Given this list of marker genes ADAMTSL2, IL21R, FLRT2, DTNA, ALDOC, SEMA3E, NTN1, DUSP2 (dual specificity phosphatase 2), SLC25A4 (solute carrier family 25 member 4), C3orf70, PARM1, TMEM59L, SORBS1, FGF18, FAM43A, PMEPA1, BEX1, ADGRE5, SBSPON, SMOC2, PLP2, CNN1, DUSP26, RAMP1, RASSF3, FBXL22, CCDC3, SVIL, NR4A2, MAPKAPK3, LRIG1, CAVIN2, ANKRD37, NR4A3, GREM2, HSPG2, ASB2, FNDC1, THBS3, TNNT3, CCN4, GEM (GTP binding protein overexpressed in skeletal muscle), KCNK3, PRKAG2, AKAP1, SSC5D, ZBTB16, IL4R, TOB1, FENDRR, KCNMA1, FOXP4, LGR6, TYRP1, ZEB1, CCND3, RASL11A, TRANK1, HHIP (NCBI Gene Id 64399), P3H2, MRGPRF, IL17B, PPP1R12B, INKA2, AQP1, SYNC, HSPB7, ENTPD1-AS1, LIMS2, LMOD1, GADD45G, COL4A5, TSPAN18 (tetraspanin 18), ANO1, DAPK3, RBM38, KLHL4, TSPAN7, ITGA10, PDLIM4, RCSD1, GBP2, MYL4, C16orf89, CCDC88C, ARL4A, ESYT2, CXADR, CRELD1, PDLIM3, FEM1C, TRIB1, TACC2, ADAMTS5, NR4A1, PLN, SEMA3C (NCBI Gene Id 222200), INHBA, HHIP-AS1, CSRNP1, FOXP2 (NCBI Gene Id 93986), BCL11A, CAP2, EPCAM, CDH13, FBXO32, BRINP3, SYT11 (NCBI Gene Id 92303), CRISPLD2, TNNT2, MBNL1-AS1, SLC29A1, DMD, NCOA6, BMF, ACTG2, ATP1A2, ANOS1, PCSK7, CD9, ADAMTS6, MYOCD, SLC8A1, NET1, SYNPO2, COL4A6 (collagen type IV alpha 6 chain), WFDC1, THAP8, ITGA9, NCKAP5, HPSE2, KANK1, SLC16A3, KCNA5, KIAA0408, KCNMB1, C1QTNF1, PFKFB3, SPEG (NCBI Gene Id 729871), CRIP1, RRAD, LTBP2, FILIP1L, PLXNA4, WNT5A, PEDS1, PBXIP1, ADAM19, SLC2A1, GALNT18, TRAF5, LAMA5, IGF1, SYNGR2 (synaptogyrin 2), ITPK1, TSPAN2, LEFTY2, BTC, RGS10, CHRDL1, PTP4A3, THBS2, MSRB3, TCEA3, ALDH1B1, MYH11, TINAGL1, FHL2, THSD4, AK4, IRAG1, TMEM255A, PLP1, SCUBE1, PDGFC, CDKN1A, ENTPD1, MTCL1, BHLHE40, TM7SF2, PNMT, SLMAP, EGLN3, NNMT, GPR20, CDC42EP3, ADAMTS8, COLGALT2, GLRB, here is a description of the gene set: from publication He P, Lim K, Sun D, Pett JP, Jeng Q, Polanski K, Dong Z, Bolt L, Richardson L, Mamanova L, Dabrowska M, Wilbrey-Clark A, Madissoon E, Tuong ZK, Dann E, Suo C, Goh I, Yoshida M, Nikolić MZ, Janes SM, He X, Barker RA, Teichmann SA, Marioni JC, Meyer KB, Rawlins EL (PMID 36493756) Human Gene Set: HE_LIM_SUN_FETAL_LUNG_C0_MID_AIRWAY_SMC_2_CELL Mid airway SMC 2 species: Homo sapiens